The following is a description of a gene set: Genes up-regulated in comparison of peripheral blood mononuclear cells (PBMC) from TIV influenza vaccinee pre-vaccination versus those at day 3 post-vaccination. Human Gene Set: GSE29617_CTRL_VS_DAY3_TIV_FLU_VACCINE_PBMC_2008_UP from publication Nakaya HI, Wrammert J, Lee EK, Racioppi L, Marie-Kunze S, Haining WN, Means AR, Kasturi SP, Khan N, Li GM, McCausland M, Kanchan V, Kokko KE, Li S, Elbein R, Mehta AK, Aderem A, Subbarao K, Ahmed R, Pulendran B (PMID 21743478) studied in species Homo sapiens Systems vaccinology has emerged as an interdisciplinary field that combines systems wide measurements and network and predictive modeling applied to vaccinology. Here we used the systems vaccinology approach to study the molecular mechanisms underlying th, and this is the list of marker genes: YTHDC1, ZHX3, PTBP2, SETD1B, FERMT2, GPC4, MAML2, CREBRF, SREK1, RANBP2, RNF103, ANKRD11, RABGGTB, LINC03043, TASOR2, IGKC, CATSPERG, LINC-PINT, COQ10B, BCLAF1, UHRF2, CHD2, PDE4B, VCPKMT, MSI2, SCGB3A1, TIAL1 (TIA1 cytotoxic granule associated RNA binding protein like 1), AKAP17A, PRRC2C, CCDC71L, DNAH6, ZBTB46, GIGYF2 (GRB10 interacting GYF protein 2), SF3A1, RICTOR, NDEL1, BRAF, GOLGA4, HIF1A, EPB41, RBP5, DCP1A, CHRNA9, RBP1, AP3M2, KDM3A, RPS23, HSD3B1 (NCBI Gene Id 3283), NECAP1, ZFP28, CCNL1, LEMD2, MYLIP, STAP2, PNLIP, NOL4L, OLFM4, GMEB2, FOXJ3, PLCL1, PHF1, NUP153, ZNF791, LINC01904, PSMA3-AS1, COLGALT2, GNE, PLK3, RAD23B, DDX52, DDX24, PARD6B, DUSP4, SIAH1, LIPG, WBP11, PRSS33, RYK, SRSF1, DYNC1LI2, DDX17, KBTBD2, RBM39, ZFYVE27, ZBTB21, SMAD4, TSKU, PIDD1, PARD3B, SNRNP200, CFAP20, JMJD1C, TUFT1, TREML5P, SMIM22, ICOS, NODAL, NGRN, ZNF92, TMEM41B, C1orf52, PPP1R16B, ZNF529, CXCR4, ERO1A, PRDM2, DDIT3, DNAAF8, QSOX2, AKAP8, HBP1, LINC00858, EXOC8, SERINC5 (serine incorporator 5), ATG2A, SMIM10L2B-AS1, POLR3E, SDE2, DHX15, SPPL2B, MIR622, PCBP2, CMPK1, PPEF1 (protein phosphatase with EF-hand domain 1), EBLN2, NHERF4, CCL20, ARID5A, BTG2, ENTPD4, RBM25, MYOT, ZBTB5, SNX29P2, L3MBTL3, USP36, SLC2A3, TIMM23, ILF3, SILC1, SLC25A28, USP42, MARCHF6, MTX3, CEP95, NAMPT, PIK3R5, MGAM, TBC1D25, INO80D, SLIT2, EML4, TAF11, STPG3-AS1, ELOA-AS1, PPTC7, RFPL1, FBXO33, PHF3, EBF3, ZFP36, ZNF236, HAPLN3, PARGP1, NR4A2, RAD21, MED6, ILKAP, SAFB2, EIF2AK3, PI3, CHORDC1, EIF4A2, CYLD, RGS1, TUBGCP5, MMP25, ZC3H10, CLK4, MEF2D, RAD21-AS1 (NCBI Gene Id 649454), HPS4, PIM3, HOOK1, BMAL1, FCHSD2, CHADL, CXorf65, RANGAP1, STK35, SNRPA1, WHAMM, MAGOH2P, JARID2, PTCD3, IST1